The following is a description of a gene set: studied in species Homo sapiens After proteins are imported into the peroxisome a subset of proteins are cleaved by the protease TYSND1. Based onmutagenesis of human TYSND1 and the homolog in Arabidopsis, TYSND1 appears to be a trypsin-like serine protease containing a conserved histidine aspartate serine triad essential for catalysis. Mice lacking Tysnd1 have reduced peroxisomal localization of some peroxisomal enzymes and exhibit reduced beta-oxidation of fatty acids and metabolism of phytanic acid. Male mice lacking Tysnd1 are sterile due to sperm that lack acrosomal caps. part of: Peroxisomal protein import Reactome Pathway: TYSND1 cleaves peroxisomal proteins, and this is the list of marker genes: SCP2, PHYH, ACAA1, TYSND1, HSD17B4, AGPS, ACOX1